Given this list of marker genes KYAT3 (NCBI Gene Id 56267), IDO2, KYAT1, IDO1, KYNU, KMO, TDO2, ALDH8A1, AFMID, AADAT, here is a description of the gene set: species: Homo sapiens Human Gene Set: GOBP_KYNURENINE_METABOLIC_PROCESS The chemical reactions and pathways involving kynurenine, the amino acid 3-(2-aminobenzoyl)-alanine.